The following is a description of a gene set: Reactome Pathway: vRNP Assembly For each of eight gene segments, a viral ribonucleoprotein (vRNP), containing a viral negative-sense RNA (vRNA) segment complexed with nucleoprotein (NP) and the trimeric influenza polymerase (PB1, PB2, and PA), is assembled in the nucleus. The vRNP functions in three modes: (1) transcription, which synthesizes viral messenger RNA from the vRNA template using as primers 5' ends of cellular mRNAs containing the cap; (2) replication, which produces positive-sense complementary RNA (cRNA) and subsequently vRNA, both complexed with NP and the trimeric polymerase; or (3), the vRNP is exported from the nucleus into the cytoplasm and is incorporated into assembling virions at the plasma membrane. species: Homo sapiens part of: Influenza Viral RNA Transcription and Replication, and this is the list of marker genes: HSP90AA1, PA, IPO5, NS, PB2, PB1, NP